Given this list of marker genes SYS1, TRAPPC5, SEC24D, VPS35L, GOLPH3L, ANK3, TMED7, GCC2, COPB1, SEC24A, NRBP1, TRAPPC2L, NKD2, RAB34, SEC24C, INSIG1, TRAPPC3, VAMP3, RANGRF, HYOU1, ERGIC3, TRAPPC1, TRAPPC8, BICD2, COPA, DNM2, LMF1, BCAP29, MYO5A, KRT18, GABARAPL2, KLHL20, PRKD1, AP1G1, RAB6B, ANXA13, LRRK2, CNIH4, PKDCC, RAB2A, CCDC22, WIPI1, SEC23IP, GOSR1, CYTH3, SURF4, OPTN, COG3, RUFY1, VAMP4, SEC24B, VAMP7 (NCBI Gene Id 6845), COPG1, OSBPL5, CEP19, BET1, TEX261, AP5Z1, RABGGTB, GGA3, MYO18A, GOPC, CTAGE1, TMED3, RABGGTA, GGA2, CREB3L2, RAB6C, PEF1, COG5, SEC31A, LMAN1L, KIF16B, RAB7B, NSF, IER3IP1, TBC1D20, LYPLAL1, VPS52, ERO1B, RBSN, COG4, VAMP2 (NCBI Gene Id 6844), BBS2, COPZ2 (NCBI Gene Id 51226), RAB6A, GAS1, GOLT1B, SEC16A, AP1G2, CTAGE8, DOP1B, TRAPPC11, PLPP3, COMMD1, VPS13C, EXOC8, LMAN2L, TMED2, CUX1, ANK1, STX5, TRAPPC3L, STX10, COPE, STXBP5, YIF1A, CRYZL2P-SEC16B, VPS41, SNX8, PHAF1, PGAP1 (NCBI Gene Id 80055), RAB10, VAMP5, SORT1, RAB33B, SNX3, BNIP1, MPPE1, EXOC6, ARCN1, YIPF6, STX6, YIPF7, ARF4, ATP2C1, ARL3, EXOC6B (exocyst complex component 6B), BLZF1, BET1L, SNX12, TMEM115, DOP1A, LMAN2, BLTP3B, RNF139, GBF1, RAB11A, SNX1, SGSM2 (NCBI Gene Id 9905), KDELR2, ARFRP1, BBS1, AP3S1, KDELR3 (NCBI Gene Id 11015), SEC31B, HTT, TAPBP, SEC22A, RAB11FIP3, RAB13, ANKFY1, VCP, ARFGAP2, SEC23B (NCBI Gene Id 980), CTAGE9, SEC22C, MYO1B, RAB1B, COG1, BCAP31, CSK, YIPF4, CORO7, RAB31, LLGL2, SPIRE1, RP2, RABIF, TRAPPC2B, SEC22B, CSNK1D (casein kinase 1 delta), ZW10, ARF3, PREPL, SNX2, ARL8B, VPS54, PRKCI, ARF5, ATP9B, ERGIC2, SORL1, RABEP1, SAR1B, TMED1, SAR1A, MAPK15, USE1, TMED6, LLGL1, ATP9A, CCDC93, KLHL12, GOLGA5, VPS13A, RAB1A, GOLGA4, SNAP23, MIA3, WHAMM, NBAS, COG7, ATL2, RAB8A, PDCD6, AMN, NAPG, RACK1, CLN3, RSC1A1, CTAGE6, TRIP11, COG2, RAB29, VPS51, VTI1A, PREB, SEC13, CUL3, TBC1D14, RER1, EPS15, GAK (cyclin G associated kinase), SCAMP3, STEAP2, LAPTM5, SCAMP1, AP1AR, EHD3, EXOC2, SCAMP2, SPIRE2, VAPA, AP3S2, TRAPPC4, SPTBN1, STEEP1, SCAP, CTAGE15, P4HB, VAPB (VAMP associated protein B and C), CTAGE4, ATL3, SORCS1, LMAN1, TMED5, CNST, AP2A1, LYPLA1, YIF1B, TRAPPC6A, PITPNB, AP4M1, RAB3IP, COPZ1, TMED4, MON2, TRAPPC9, TMED9, RAB41, KDELR1, GOSR2, EXOC5, TRAPPC2, RAB14, AP3D1, COG6 (component of oligomeric golgi complex 6), MIA2, TRAPPC6B, EXOC1, TFG, CIDEB, CCDC91, TRAPPC10, PPP6C, RAB4B, RAB26, ARFGEF2, COPG2, SCFD1, ACSL3, LAMP1, GOLGA7, RINT1, GOLT1A, KIF1C (NCBI Gene Id 9713), STXBP5L, YKT6, USO1, MACF1, SCYL1, YIPF5, TRAPPC13, GOLGA2, GGA1, GOLPH3, SPAST, ARFGAP3, STX17, SEC16B, COG8, ERGIC1, STX18, UVRAG, EXOC4, VTI1B, RAB6D, NAPA, TRAPPC12, KIF13A (kinesin family member 13A), SEC23A, COPB2, TMED10, here is a description of the gene set: The directed movement of substances into, out of or within the Golgi apparatus, mediated by vesicles. Human Gene Set: GOBP_GOLGI_VESICLE_TRANSPORT species: Homo sapiens